The following is a description of a gene set: species: Homo sapiens from publication Busslinger GA, Weusten BLA, Bogte A, Begthel H, Brosens LAA, Clevers H (PMID 33691112) Human Gene Set: BUSSLINGER_DUODENAL_K_CELLS, and this is the list of marker genes: HERC2P7, TMCO3, BCL9L, PLPP5, GOLGA7, PRRG4 (proline rich and Gla domain 4), KCTD12, SLC29A4, STX1A, CACNA1A, SOCS3, SCG5, SCG2, DEPP1, HAP1, CHGA (chromogranin A), ZMIZ2, SCGN, GIP, ORC5